The following is a description of a gene set: Mouse Gene Set: GOBP_CELLULAR_RESPONSE_TO_TOXIC_SUBSTANCE Any process that results in a change in state or activity of a cell (in terms of movement, secretion, enzyme production, gene expression, etc.) as a result of a toxic stimulus. species: Mus musculus, and this is the list of marker genes: Aldh2, Slc22a1, Ptgs1, Mtarc1, Txn1, Cd36, Nxn, Mpo, Slc29a4, Prdx6b, Prdx4, Cyp1b1, Gsr, Mtarc2, Cdh13, Aldh1a1, Gfer, Gch1, Rab29, Gpx2, Selenow, Tpo, Tnf, Selenot, Gpx3, Pim1, Apom, Park7, Apoe, Txndc17, Gstt1, Txnrd2, Gstm5, Prkn, Sesn2, Esd, Ptgs2, Ahr, Abtb2, Dhfr, Kdm3b, Lpo, Nnt, Gsto2, Prdx1 (peroxiredoxin 1), Txnrd1, Atp7a, Ppp1r9a, Slc39a8, Sod1, Epx, Gpx8, Gstm7, Trp53inp1, Prdx6, Rdh12, Gpx4, Cp, Cers1, Ccs, Selenos, Prdx2, Txnrd3, Mb, Nfe2l2, Slc11a1, Akr1a1, Fabp1, Prxl2a (peroxiredoxin like 2A), Abcb6, S100a9, Nos3, Ubiad1, Prxl2b, Sesn1, Gsto1, Nqo1, Rdh11, Hp, Gstm3, Fancc, Slc22a2, Gpx7, Gpx5, Ednra, Edn1, Pxdn, Mgst3, Abcb1a, Slc22a3, Upk3bl, Prdx5, Fbln5, Gpx1, Cat, Gstk1, Lancl1, Aifm2, Mt3, Aldh1a7, Mgst2, Apoa4, Pink1, Prdx3, Oprd1, Mapk1, Mapk3, Gsta1, S100a8, Trpa1, Sod3, Srxn1, Kcnc2, Gpx6, Ambp, Rab40b, Adh4, Adh5, Ptges, Gstm6, Aqp8, Cygb, Sod2